The following is a description of a gene set: studied in species Mus musculus Mouse Gene Set: GOCC_VACUOLAR_PROTON_TRANSPORTING_V_TYPE_ATPASE_V0_DOMAIN The V0 domain of a proton-transporting V-type ATPase found in the vacuolar membrane., and this is the list of marker genes: Atp6v0e2 (NCBI Gene Id 76252), Atp6v0d1, Atp6v0a4, Atp6v0a2, Atp6ap2, Atp6v0c, Atp6v0b, Atp6v0a1, Rnasek